Given this list of marker genes DLGAP5, MAML3, EP300, MAML1, STAT1, FABP7, MAML2, PTCRA, NOTCH3, HES5, WWC1, KAT2A, HEY2, KAT2B, MAMLD1 (mastermind like domain containing 1), RBPJ, PBX1 (PBX homeobox 1), PLXND1, HES1, IKZF1 (IKAROS family zinc finger 1), CREBBP, NOTCH1, HEY1, SNW1, HEYL, here is a description of the gene set: Human Gene Set: REACTOME_NOTCH3_INTRACELLULAR_DOMAIN_REGULATES_TRANSCRIPTION species: Homo sapiens NOTCH3 Intracellular Domain Regulates Transcription